Given this list of marker genes ABCD1, PSEN1, PMS2, COQ7, PIK3CA, TYROBP, ATM, APP, GRN, BMPR1A, SEMA4A, RPS20, APOE, EPRS1, PSEN2, ABCA7, TMEM106B, TOMM40, ATP6AP2, TREM2, TGFBR2, TRANK1, CHMP2B, SORL1, CEP85L, POLD1, POLE, KRAS, MSH6, MLH1, MAPT, MSH2, EPCAM (NCBI Gene Id 4275), MUTYH, BRCA2, PMS1, CHEK2, here is a description of the gene set: studied in species Homo sapiens Abnormal interpretation of external stimuli Abnormal perception of reality is characterized by an abnormal or inaccurate experience of external stimuli. Human Gene Set: HP_ABNORMAL_INTERPRETATION_OF_EXTERNAL_STIMULI